The following is a description of a gene set: Human Gene Set: CREB3L2_TARGET_GENES from publication Yevshin I, Sharipov R, Kolmykov S, Kondrakhin Y, Kolpakov F (PMID 30445619) Genes containing one or more binding sites for (CREB3L2) in their promoter regions (TSS -1000,+100 bp) as identified by GTRD version 20.06 ChIP-seq harmonization. species: Homo sapiens, and this is the list of marker genes: NME1-NME2, LAPTM4A, ZNF687, EME1, METTL25, DMAP1, TIMM9, RPL35A, CCDC59, ZRANB2-DT, H2BC15, PSMA3-AS1, TBC1D8B, ZNF561 (zinc finger protein 561), CAGE1, CLDN4, SRRM5, CCDC66, FAM53C, DUT, HBP1, COPZ1, MORF4L2-AS1, PTBP1, ZNF561-AS1, GFM2, CSTF3-DT, BBS4, RECQL, SLC52A3, H4C5, MRPL27, AURKB, ZRANB2, SREK1IP1, SPTLC2, EIF2AK3-DT, RPL27, AP2B1, ISY1-RAB43, SEC23B (NCBI Gene Id 980), ZNF687-AS1, IQCG, SP1, PDCD10, NOL6, TUBA1B-AS1, FKBP14 (NCBI Gene Id 55033), SEC24C, NCSTN, TARS1, IRGQ, ADAMTS7P4, MAGOHB, CIC, RPL8, MED8, EIF2B5, UFL1-AS1, EFCAB6, SNORD95, EIF2B5-DT, PPP2R5E, ZNF460, ENSG00000261335, DSN1, LSM8 (LSM8 homolog, U6 small nuclear RNA associated), RPL37 (ribosomal protein L37), CASD1, PRANCR, SPAG7, RACK1, RIOK1, GUCD1, PLEKHA8, CFAP298, CD164, WRAP53, DNM2, SZT2, ADPRHL1, MIR4512, GOLGB1 (golgin B1), EIF2A, H2AC12, ISY1, RBM39, BTG3-AS1, LNP1, MRPL17, ARID4A, RPA2, LAPTM4A-DT, ANAPC13, TTC1, COPA, PTCD2, MORF4L2, SNRPD3, CWC22, FLAD1, ZNF394, CEP63, WDR89, PRKCI, TOMM70, POC5, ARMH4, HNRNPA1, FNTB, KDM8, HIGD2A, CFAP298-TCP10L, ZNF581, MIR638, NOP16, SERPINI1, EIF2AK3, SF3A3 (splicing factor 3a subunit 3), BPGM, NSA2, CNOT2, TM9SF4, KIAA0586 (KIAA0586), MRPS27, TRMT13, NME1, RNA5SP146, SERP1, ZSWIM1, MAP3K14, SPATA46, ZNF580, HMGCS1, TARS1-DT, TUBA1B, ZNF576 (NCBI Gene Id 79177, zinc finger protein 576), GOLT1B, NR1D1, CWC27, PJA2, EFCAB6-DT (EFCAB6 divergent transcript), WDR11, PRKAR1A, RFX1, ABCB8, ALKBH7, ZNF165, WDR11-DT